The following is a description of a gene set: Base-Excision Repair, AP Site Formation studied in species Homo sapiens Human Gene Set: REACTOME_BASE_EXCISION_REPAIR_AP_SITE_FORMATION, and this is the list of marker genes: H4C3, MPG, TDG, NTHL1, H4C14, H2AC14, UNG, H2BC21, ACD, H2BC10, H2BC1, H4C11, H2BC7, MBD4, H4C2, NEIL3, H2AC7, H2BC17, H2BC12L, H2BC5, H4C1, POT1, H4C15, H2BC9, H2BC4, TERF2IP, OGG1, H4C6, TERF1, H2AC6, H2AB1 (NCBI Gene Id 474382), H2BC14, SMUG1, H2BC13, H2BC15, H2BC8, H2AC20, H2BC12, H4C4, H4C12, NEIL1, H2BC3, H4C16, H2BC26, H2AC18, H2AX, MUTYH, H2AC19, TINF2, H2BC11, H2AC4, H2AC8, H2AZ2, H4C9, H3-4, H2BC6, H4C13, H4C5, H4C8, TERF2, NEIL2, H2AJ